Given this list of marker genes WNT6, PDGFA, SHH (NCBI Gene Id 6469), SMO, BMP4 (bone morphogenetic protein 4), here is a description of the gene set: Human Gene Set: GOBP_EPITHELIAL_MESENCHYMAL_CELL_SIGNALING species: Homo sapiens Any process that results in the transfer of information from an epithelial cell to a mesenchymal cell where it is interpreted.